Given this list of marker genes NUTF2, SEPTIN3, DPF1, DMD, PPP1R9B, LAG3, EPOR, PPTC7, IER5L, BICRA, COL11A1, NRDC, P2RY4, FOXP1, TSC22D2, EN1, TOMM5, TRPM7, TMEM62, ZBTB18, IGF1, HES6, GSX1, BAZ2A, STARD3, DALRD3, GRIN2D, ZBTB47, SLC26A9, NEUROD2, CTDSPL, RARA, KCNE3, KCNG4, LURAP1L, HRC, FKBP3, MTMR3, NDUFA4, NDUFB8, KLF15, PTPRS, ZEB1, VEGFA, SEMA7A, CARMIL3 (capping protein regulator and myosin 1 linker 3), OAZ2, RIT2, TTC9C, GSC, SORBS1, MYPN, MAP3K5 (mitogen-activated protein kinase kinase kinase 5), SLC48A1 (NCBI Gene Id 55652), PJA2 (praja ring finger ubiquitin ligase 2), AKTIP, NR1H2, DNAJB5, KCNJ2, EYA1, CACNG6, HOXA11 (homeobox A11), LMO1, PPARGC1B, NTN3, DNAI1, SNAP25, RGS8, SMARCA1, TMEM178A, MAPRE3, CCDC136, SESN2, POU4F1, MIS12, ZMYM4, RUSC1 (NCBI Gene Id 23623), LOXL4 (lysyl oxidase like 4), UNC13B, PTPRT, HYAL2, PCBP2, PGGT1B, WNT6, LIN28A, USP2, PLEC, PABIR2, LLGL2, GASAL1, PPP2R5E, SALL1, SMPX, SULT2B1, ATP4A, LTBP1 (NCBI Gene Id 4052), HSD3B7, OTOF, NKX2-1, DLX1, GDPD2, H1-0, SOX11, TUBA1C, CDH13, TFAP4, KCNK5, SNCA, EVX1, PSMD3, LMO3, ZNF800, DNAJC14, CNTLN, ADGRB2, CIDEC, CSMD3, NAB2, SPRY4, ATP8A1, SH3BP1, TMT1B, GATA1, GPBP1, KIF3C, ITPKC, FMO5, ANGPTL2, HOXA10, PDIA3, GPC4, RASL10B, ASIC5, SRRM3, UBE2K, DUSP7, NIPBL, DLG2, TONSL, HAPLN2, CLIC1, MAP3K3, SKIDA1, HOXC4, SOST, GRK2, EIF4E, CMKLR1, DDIT3, RRP36, TSPAN32, RAB25, ANGEL1, NFIB, UCP3, TCF7, STIMATE, RAP2C (NCBI Gene Id 57826), KCNH2, CDK16 (cyclin dependent kinase 16), CBFA2T2, SLC39A2, CRB1, NAV3, LRP1, ZMAT3, HMGN2, TPPP3, PCSK1, PTK2, POLR3E, TLE3, CLPS, BCL11A, EPN2, ANGPTL7, RELCH, TNRC6C, SEMA4C, RAPSN, BOLA3, DPH1, HEXIM2, DCAF11, ANK2, CACNB2, NPHP4, STARD10, TLR7, NUDT3, RTL9, MASP1, FGF16, FAM219A, PFDN5, VEZF1, CHD6, NDUFAF3 (NADH:ubiquinone oxidoreductase complex assembly factor 3), NR5A1, LBX1, CLEC4D, ALPK2, PRICKLE1, TYRO3, GOLM2, KRTCAP2, JMJD1C, RUSC1-AS1, FLYWCH1 (FLYWCH-type zinc finger 1), NHSL2, PCDH1, SH2B3, NDNF, RWDD4, CDK6, ELL2, PLEKHA6, RASGEF1A, RHOG, GRM7, ETNK2 (NCBI Gene Id 55224), CELF4, SGMS1, COQ8B, NXPH1, FLT3LG (NCBI Gene Id 2323), SYNC, ACVR1C, ARFIP2 (ADP ribosylation factor interacting protein 2), STAT3, PITX2, ERLIN2, COL4A3, CELF1, PI4KB, ESRP2, SOX15, SIN3A, POLD4, NR4A2, MAPK8IP1, ZNF385A, PDE3A, SSBP2, TRAPPC11, PPM1J, DOC2A, ADO, MIDEAS, TP53BP1, PCSK4 (proprotein convertase subtilisin/kexin type 4), GSK3B, SMAD7, TIMM10B, TRIM46, MYO18A, SERPINE1, MCTP2, OPCML (NCBI Gene Id 4978), PCBP4, MOAP1, ABTB3, CABP2, PHF23, COL4A4, SLC22A17, SGCG, here is a description of the gene set: Human Gene Set: AP4_01 species: Homo sapiens Genes having at least one occurrence of the motif WGARYCAGCTGYGGNCNK in the regions spanning 4 kb centered on their transcription starting sites. This matches the TFAP4 transcription factor binding site V$AP4_01 (v7.4 TRANSFAC).